Given this list of marker genes Sema5a, Comp, App, Lrrtm4, Cfhr4, Lipc, Slit2, Pla2g2d, Ptprc, Itgam, Lpl, Cfh, Chrd, Ptprs, Psg23, Hrg, Apoe, Hpse2, Agrn, Fst, Grem1, Fbln7, Atp1a3, Psg17, Slit1, here is a description of the gene set: species: Mus musculus Binding to a heparan sulfate proteoglycan, any proteoglycan containing heparan sulfate as the glycosaminoglycan carbohydrate unit. Mouse Gene Set: GOMF_HEPARAN_SULFATE_PROTEOGLYCAN_BINDING